The following is a description of a gene set: studied in species Homo sapiens Human Gene Set: WP_OSX_AND_MIRNAS_IN_TOOTH_DEVELOPMENT OSX and miRNAs in tooth development, and this is the list of marker genes: MIR586 (NCBI Gene Id 693171), MIR34AHG (NCBI Gene Id 106614088), ALPL, CTNNB1, MIRLET7D, MIRLET7E, BMP7, MIR204, SOST, MIR211, MIRLET7F2, MIR885, MIRLET7C, DMP1, MIR145 (microRNA 145), NOTCH4, SP7, MIRLET7G, MIR29B1, DSPP, MIRLET7A2, MIR338, KLF4, NOTCH2, MIR32, DKK1, HNF1A, MIRLET7A1, MIRLET7I, NOTCH1, NOTCH3, MIRLET7F1, RUNX2, MIR143